Given this list of marker genes ARHGEF1, GNA12, GNA13, P2RY8, ADGRG1, ARHGEF12, ADGRL3, here is a description of the gene set: A G protein-coupled receptor signaling pathway in which the signal is transmitted via the activation of Rho activity. Rho is a family of small (~21 kDa) signaling G proteins that include RhoA, Cdc42, and Rac1. studied in species Homo sapiens Human Gene Set: GOBP_RHO_ACTIVATING_G_PROTEIN_COUPLED_RECEPTOR_SIGNALING_PATHWAY